The following is a description of a gene set: species: Homo sapiens Inflammation of the uveal tract in which the primary site of inflammation is the anterior chamber. Human Gene Set: HP_ANTERIOR_UVEITIS Anterior uveitis, and this is the list of marker genes: HLA-DRB1, AIRE, IL2RB, IKBKG, PTPN22, PTPN2, MIF, STAT4, HLA-B, STUB1, ANKRD55, IL2RA, LACC1, IL6, TNFAIP3, FAS, NOD2, CD247